The following is a description of a gene set: Any process that activates or increases the frequency, rate or extent of the chemical reactions and pathways resulting in the breakdown of a protein by the destruction of the native, active configuration, with or without the hydrolysis of peptide bonds. species: Homo sapiens Human Gene Set: GOBP_POSITIVE_REGULATION_OF_PROTEIN_CATABOLIC_PROCESS, and this is the list of marker genes: FBXO22, DTL, AXIN2, MSN, NFE2L2, SIRT2, NUPR1, DVL1, CDKN1B, DDB1, PACSIN3, UBQLN2, HSPBP1, XBP1 (NCBI Gene Id 7494), CHFR, C4BPB, ZYG11B, SNX1, TREM2, TMTC3, WFS1, ZER1, GGA1 (golgi associated, gamma adaptin ear containing, ARF binding protein 1), BCAP31, CSNK2A1, FMR1, SOX17, GABARAP, ASB9, KCNE2, FZR1, ZFAND2A, IER3, LRP1, SOX9, FOXO1, ITCH, RDX, PSMC3, NKD1, OAZ3 (NCBI Gene Id 51686), PABIR1, PLK1, PSMC6 (proteasome 26S subunit, ATPase 6), VCP, ECSCR, ELOB, ZNF268, PLK3, PRICKLE1, CSNK1D, SNX9, UBXN2A, NEURL3, FBXW7, GPC3, BAG2, SOCS5, RACK1, SEC22B, RGMA, TNFAIP3, TRIB1, DCAF1, RCHY1, CSNK2A3, PAQR3, WNT5A, RNF41, MDM2, SGSM3, CLU, TAF1, ATG7, PIAS1, PLK2 (polo like kinase 2), CREBRF, SOCS4 (NCBI Gene Id 122809), SMAD7, KLHL40, ASB11, TRIB3, GGA3, ATXN3L, APOE, ATXN3, CBFA2T3, IL1B, RNFT2, CSNK1E, LRRK2, DET1, RAB7A, APP, C4BPA, SGTA, DDA1, HSP90AA1, CUL4A, LRP2, SUMO1, DNAJB2, TMEM259, IDE, GPLD1, SH3D19, CSNK1A1, DAB2IP, GCLC, VPS35 (NCBI Gene Id 91808), OAZ2, CDC20, MYLIP, ABCA2, KEAP1, BAG6, TRIB2, SIRT6, STUB1, SORL1, TF, DACT1, MARCHF2, OSBPL7, SH3RF3, STX5, HSPA1A, GSK3A, MAPK9, NDUFA13 (NADH:ubiquinone oxidoreductase subunit A13), DAOA, AKT1, SNX33, CEBPA (NCBI Gene Id 1050), TRIM32, BBS7, IFNG, FBXL5, DDRGK1, ADAM9, COP1, PPP2R3A, RNF185, SNF8, USP13, RAD23A, ADRA2A, UBR3, IL33, PSEN1, NDFIP1, SIRT1, CAV1, ASB5 (NCBI Gene Id 140458), FBXW8, USP5, HAMP, TNFRSF1B, RNF128, HERPUD1, VGLL4 (NCBI Gene Id 9686), MIR181B1, PSMC5, HSPA1B, CUL4B (NCBI Gene Id 8450), TNF, LPCAT1, EGLN2, UBQLN1, NOP53, CBLB, PSMC1, BARD1, AURKA, OAZ1, PSMD10, PCSK9, SH3RF1, RNF180, PSMC4, RNFT1, NEDD4L, HECTD1, LDLR (NCBI Gene Id 3949), PRKN, RBX1, AMER1, NRDC, RFPL1, PSMC2, VPS11, VPS28, SUMO2, VIP, FURIN, NSF, TNFSF12, RHBDD3, ADAM8, AXIN1, EZR, CD81, GSK3B, FAF1, GBA1, NUB1, RHBDD1, NEDD4, TIPARP, RILP, SH3RF2, CDC20B, NKD2, APC, TMX1, DAB2